The following is a description of a gene set: IRS activation studied in species Homo sapiens Human Gene Set: REACTOME_IRS_ACTIVATION, and this is the list of marker genes: GRB10, INSR, IRS1, IRS2, INS